Given this list of marker genes EDNRB, IL1B, TRPV1, TNFRSF11A (TNF receptor superfamily member 11a), TNF, PTGS2, PTGES, IL1A, TNFSF11, PTGER3, here is a description of the gene set: Human Gene Set: GOBP_FEVER_GENERATION The heat generation process that results in a rise in body temperature above the normal, often as a response to infection. studied in species Homo sapiens